The following is a description of a gene set: species: Mus musculus Mouse Gene Set: GOBP_NEGATIVE_REGULATION_OF_CELL_SUBSTRATE_ADHESION Any process that decreases the frequency, rate or extent of cell-substrate adhesion. Cell-substrate adhesion is the attachment of a cell to the underlying substrate via adhesion molecules., and this is the list of marker genes: Hoxa7 (NCBI Gene Id 269740), Men1, Dusp22, Dlc1, Src, Mmp12, Plet1, Acer2, Rhoa, Ap1ar, Myoc, Spry4, Ptpn1, Efna5, Postn, Acvrl1, Mmp14, Fzd4, Nexmif, Muc4, Adam15, Plg, Apod, Ptprz1, Phldb2, Sema3e, Rcc2, Tbcd, Notch1, Ajap1, Meltf (melanotransferrin), Coro2b, Kank1, Serpine1, Arhgap6, Tacstd2, Rasa1, Clasp2, Angpt2, Fzd7, Lgals1, Cask, Cdkn2a, Coro1c, Col1a1, Thbs1 (NCBI Gene Id 21825), Spock1, Pten, Dmtn, Wnt1, Enpp2, Bcl6, Lrp1, Jag1, Gcnt2, Bcar1, Muc21, Nf1, Pik3r1, Itgb1bp1 (integrin beta 1 binding protein 1), Fbln1, Fam107a, Actn4